The following is a description of a gene set: Any structural abnormality of the left ventricle of the heart. species: Homo sapiens Human Gene Set: HP_ABNORMAL_LEFT_VENTRICLE_MORPHOLOGY Abnormal left ventricle morphology, and this is the list of marker genes: TNNI3, FHL1, NEXN, DBR1, GNPTAB (N-acetylglucosamine-1-phosphate transferase subunits alpha and beta), MT-TL1, CAV3, FZR1, MYPN, SMAD3, BUB1B, MT-TV, TNNT2, NAXD, ARSK, SDHA, GNB2, SCO1, MYH7, PTPN11, CHST3, POLG2, COQ9, NEK8, WDR35, GLRX5, MT-CO3, MYOZ2, SMAD6, MYLK2, POLG, POMT2, SPEG, C1QBP, MT-TK, HCN4, PIGA, TTR, ACTN2, SCN5A, PIGL, MT-CO2, SYT2, GYS1, ATP6AP2, MYL2, COG1, IFIH1, LOX, MT-TF, COQ7, FLNC, SLC25A24, PSEN1, ABCC9, JPH2, MYL3, SDHD, SDHB, TWNK, HADHB, KCNJ5, MT-CYB, RIT1, MEN1, ZNF462, AIP, PLN, TCAP, MT-ND1, GATA6, GAA, MTX2, EPG5, MT-TW, BUB1, MOGS, ADAM17, TLL1, FBXL4, DMD, ARL6, GTPBP3, BIN1, BUB3, ALG9, SLC25A4, HADHA, HSD11B2, NDUFS2, TTN, PSEN2, LDB3, NPPA, ZNF687, NONO, FOCAD, FGFR1, MT-ND6, CEP57 (centrosomal protein 57), TRMT10C, DTNA, POMT1, LRPPRC (leucine rich pentatricopeptide repeat containing), ABCA1, INSR, MT-TC, RRM2B, NKX2-5, ESPN, TRIP13, EGFR, MT-TS2, ACTC1, BBS1, RNU7-1 (RNA, U7 small nuclear 1), TAB2, FKRP, HDAC4, MT-CO1, NOTCH1, COL1A2, CCDC28B, MYH6, ADAMTS19, ZIC3, COX16, SVIL, GLA, B3GAT3, MT-TQ, RYR1, LZTR1, CACNA1D, MT-ND5, GATA5, WDPCP, SDHAF1, TPK1